Given this list of marker genes Lmna, Parp1, Mir143, Sorl1, Spi1, Plaat3, Pparg, Trpm4, Nr1h4, Mir103-2, Prkaa1, Nmnat1, Ncoa2, Klf7, Ncoa1, Pou4f2, Mir103-1, Lpl, Sirt1 (sirtuin 1), Sh3pxd2b, Ghrl, here is a description of the gene set: Mouse Gene Set: GOBP_REGULATION_OF_ADIPOSE_TISSUE_DEVELOPMENT studied in species Mus musculus Any process that modulates the frequency, rate or extent of adipose tissue development.